The following is a description of a gene set: Mouse Gene Set: REACTOME_SYNTHESIS_OF_BILE_ACIDS_AND_BILE_SALTS_VIA_7ALPHA_HYDROXYCHOLESTEROL Synthesis of bile acids and bile salts via 7alpha-hydroxycholesterol species: Mus musculus, and this is the list of marker genes: Ncoa2, Hsd17b4, Cyp7a1, Cyp8b1 (cytochrome P450, family 8, subfamily b, polypeptide 1), Acot8, Rxra, Cyp27a1, Akr1c20, Abcb11, Akr1c21, Slc27a5, Amacr, Baat, Akr1d1, Akr1c6, Nr1h4, Hsd3b7 (NCBI Gene Id 101907), Acox2, Slc27a2, Scp2, Ncoa1, Cyp7b1